Given this list of marker genes Shh, Nkx3-1, Sox9, Ar, Apc, Cdkn1b, Stk11, Serpinf1, Eaf2, Notch1, Ctnnb1, Wdr77, here is a description of the gene set: The multiplication or reproduction of epithelial cells, resulting in the expansion of a cell population that contributes to the progression of the prostate gland over time. Mouse Gene Set: GOBP_EPITHELIAL_CELL_PROLIFERATION_INVOLVED_IN_PROSTATE_GLAND_DEVELOPMENT studied in species Mus musculus